The following is a description of a gene set: Genes predicted to be targets of miRBase v22 microRNA mmu_miR_3063_5p in miRDB v6.0 with MirTarget v4 prediction scores > 80 (high confidence targets). from publication Chen Y, Wang X (PMID 31504780) Mouse Gene Set: MIR_3063_5P species: Mus musculus, and this is the list of marker genes: N4bp2l1, Ywhaq, Fhod3, Fndc1, Atcay, Tmem140, Irf2bp2, Gm3558, Chrna9 (cholinergic receptor, nicotinic, alpha polypeptide 9), Acsl4, Tmem92, Ccdc43, Panx3, Uhrf2, Dnase1l3, Vtcn1, Lrrc55, Celsr2 (cadherin, EGF LAG seven-pass G-type receptor 2), Gm3383, Slc25a36, Ankrd40, Rnft1, Smim33, Gm6710, Rufy1, Clpb, Slc30a9, Cntn3, Gm11544, Mob1b, Cd160, 1700012B07Rik, Spopl, Pgr, Cdkn2b, Tktl1, Ppic, Actr3 (ARP3 actin-related protein 3), Gm3411, Ola1, Raver1, Pip4k2b, 2010003K11Rik (NCBI Gene Id 69861), Mzf1 (NCBI Gene Id 53862), Rab9b, Chsy1, Adcy7, Cd86, Tfip11, Tmem201, 4930555G01Rik, Smc2, Gm3696, Nr1d2, Gm5796, Slitrk2, Rhbdd2, Hs3st4, 2210418O10Rik, Rps27l, 2610042L04Rik, Derl1